Given this list of marker genes Ahr, Hmox1, Cyp4a12a, Cyp2u1, Cyp4a12b, Cyp4f15, Cyp4f14, Cyp4a10, Cyp4f18, here is a description of the gene set: Mouse Gene Set: GOMF_ARACHIDONATE_OMEGA_HYDROXYLASE_ACTIVITY Catalysis of the reaction: (5Z,8Z,11Z,14Z)-eicosatetraenoate + O2 + reduced = 20-hydroxy-(5Z,8Z,11Z,14Z)-eicosatetraenoate + H+ + H2O + oxidized. (5Z,8Z,11Z,14Z)-icosatetraenoic acid is also known as arachidonic acid is also and 20-hydroxy-(5Z,8Z,11Z,14Z)-eicosatetraenoate as 20-HETE. studied in species Mus musculus